The following is a description of a gene set: Human Gene Set: HP_UPPER_LIMB_AMYOTROPHY studied in species Homo sapiens Upper limb amyotrophy Muscular atrophy involving the muscles of the upper limbs., and this is the list of marker genes: INF2, UBAP2L, RYR1, CEP126, ALS2, DYSF, TNR, PDK3, SQSTM1, CPLANE1, WARS1, ADAMTS15, NOTCH2NLC, ADSS1, GARS1 (glycyl-tRNA synthetase 1, NCBI Gene Id 7972), VCP, MATR3, GBF1, DCTN1, MORC2, SLC25A21, SLC52A3, HMGCR, KANSL1, KAT6A, TIMM8A, HSPB3, IDUA, SPG11, CADM3 (NCBI Gene Id 57863), FXN, GIPC1 (GIPC PDZ domain containing family member 1), NEB, ACTA1, GDAP1, HINT1, KY, RTN2, PMP22, NEFL, SCO2, HSPB1, ANO5, ITPR3, KIF1A, BSCL2, FLNC, CAV3, TIA1, PAX3, REEP1, GJB1, PLOD3, SPTAN1, TRPV4 (transient receptor potential cation channel subfamily V member 4), MARS1, NEFH, TFG, KIF5A, FBLN5, KLHL9, CYP7B1 (cytochrome P450 family 7 subfamily B member 1), COMP, MPZ, CHCHD10, NDRG1, LMNA, LRP12, SLC39A13, GNB4, LDB3, NGLY1, TRIM2, SEPTIN9, SVBP, SLC12A6, SPTLC1, MFN2, CHRNA1, HK1, HARS1, SLC5A6, PRX, RILPL1, JAG1, MPV17